Given this list of marker genes Ywhag (tyrosine 3-monooxygenase/tryptophan 5-monooxygenase activation protein, gamma polypeptide, NCBI Gene Id 52802), Bad, Sfn, Bid, Ywhaq, Ppp3r1, Ywhae, Bcl2, Ywhah, Ywhaz, Ppp3cc, Ywhab, here is a description of the gene set: Mouse Gene Set: REACTOME_ACTIVATION_OF_BAD_AND_TRANSLOCATION_TO_MITOCHONDRIA species: Mus musculus Activation of BAD and translocation to mitochondria